The following is a description of a gene set: from publication Darwiche N, Ryscavage A, Perez-Lorenzo R, Wright L, Bae DS, Hennings H, Yuspa SH, Glick AB (PMID 17525749) studied in species Mus musculus Human Gene Set: DARWICHE_PAPILLOMA_RISK_HIGH_UP Genes up-regulated during skin tumor progression from normal skin to high risk papilloma. Chemical induction of squamous tumors in the mouse skin induces multiple benign papillomas: high-frequency terminally benign low-risk papillomas and low-frequency high-risk papillomas, the putative precursor lesions to squamous cell carcinoma (SCC). We have compared the gene expression profile of twenty different early low- and high-risk papillomas with normal skin and SCC. Unsupervised clustering of 514 differentially expressed genes (P<0.001) showed that 9/10 high-risk papillomas clustered with SCC, while 1/10 clustered with low-risk papillomas, and this correlated with keratin markers of tumor progression. Prediction analysis for microarrays (PAM) identified genes that distinguished the two papilloma classes, and a majority of these had a similar expression pattern in both high-risk papillomas and SCC. Additional classifier algorithms generated a gene list that correctly classified unknown benign tumors as low- or high-risk concordant with promotion protocol and keratin profiling. Reduced expression of immune function genes characterized the high-risk papillomas and SCC. Immunohistochemistry confirmed reduced T-cell number in high-risk papillomas, suggesting that reduced adaptive immunity defines papillomas that progress to SCC. These results demonstrate that murine premalignant lesions can be segregated into subgroups by gene expression patterns that correlate with risk for malignant conversion, and suggest a paradigm for generating diagnostic biomarkers for human premalignant lesions with unknown individual risk for malignant conversion., and this is the list of marker genes: RNASE2, CACYBP, FTL, SMIM8, AXL, RACGAP1 (Rac GTPase activating protein 1), PFKL, NHP2, GDF5, PGAM1, CSPP1, TMEM248, PLEKHA4, PRG3, LRIF1, SPNS3, TXN, VHL, TMEM65, ACOT9, RPS6KA4, BID, VPS37A, GKN3P, HSPD1, MRPS18A, CCT4, RPL39, RPTN, S100A9, TRAF2, BZW1, CXCL16, IL36A (interleukin 36 alpha), ID1, CEACAM21, ESD, LTB4R, MT1F, EEF1D, SERPINB4, SARAF, CRELD1, NEK4, IL1B, TGFA, CD248, SSU72, FAM162A, KLF13, STX16, RPS3A, HEXA, IDE, CMPK2, ENAH, RASIP1, PDS5B, TRMT1, SAMHD1, KPRP, RHOH, NCL, HOMER3, MORN5, S100A11, TNFRSF25, CCDC38, SPRR2A, LYPD2, GCLM, ENO1, RAB5IF, NCAN, HRC, DNAJC1, EEF1B2, CLVS1, CHI3L1, CALML5, COX19, CX3CL1, GSTA1, COX5B, SELENOT, S100A8, LDHA, HAMP, PPIC, RUBCN, SNHG9, ART5, SLPI, NRSN1, PDCD5, MCAM, ACAN, SNHG3, EML4, RAB2B, CSTA, SPIC, SRSF1, SUN1, FOXL2, EXT2, ARG1, HBS1L, H2AZ1, MAP6, PTPRCAP, TP73, GSK3B, SUCLG2, CACNA1E, QDPR, ELAVL1, SFPQ, PRRC1, FABP4, CHKA, BBLN, FES, ELAPOR1, JAG1, LIF, HBE1 (hemoglobin subunit epsilon 1), CAMK4, NFE2L2, LCE3B, SFN, DYNLL1, ENG, MGAT1, GALK1, GPR15LG, WFDC2, BATF3, SDR9C7, PMEPA1, SRM, IFITM3, PGK1, LY6E, KLK6, RYR1, ICAM1, CHPT1 (choline phosphotransferase 1), UBE2C, KLK9, DRD5